Given this list of marker genes Cct6a, Xlr, Hpcal4, Gprin3, Prr14l, Zfp175, Pask, Orc2, Col19a1, Kynu, Zfp280d, Emilin3, Rragc, Bcl10, Spata13, Plxnb3, Prkacb (protein kinase, cAMP dependent, catalytic, beta), Nipbl, Grin1, Tufm, Slc27a1, Orai1, Dhdh, Stxbp2, Ap3b2, Kcnj4, Setbp1, Adgrf2, Pogz (pogo transposable element with ZNF domain), Zswim4 (zinc finger SWIM-type containing 4), Col6a1, Tomm70a, Semp2l1, Plcxd3, Eri2, Alas1, Vsig10, Hspb7, Brcc3, Exph5 (exophilin 5), Rffl, Szrd1, Ctnnd1, Il2ra, Arhgap32, Nsun6, Mllt6, Ahsg, Slc35f1, Acly, Arc, Phaf1, Nme2 (NCBI Gene Id 18103), Ankib1, Rap1gds1, Lyg1, Vps13b, Brat1, Zfp174, Tcta, Senp2, Tab2, St8sia6, Mllt10, Cmtm8, Asb15, Ica1l, Cdk18, Mecp2, Heca, Klhdc7a, Stx5a, Trim16, Nphs2, Syt12, Oscar, Sox14, Mras, Casp2, Metrnl, Skap1, 6430550D23Rik, Slc49a4, Hsbp1l1, Pptc7, Hs3st3b1, Pex14, Cyp2s1, Itga5, Ppp1r10, Creg2, Cd3d, Fads1, Mrgprb2, Cdc14b, here is a description of the gene set: from publication Chen Y, Wang X (PMID 31504780) Mouse Gene Set: MIR_7055_5P species: Mus musculus Genes predicted to be targets of miRBase v22 microRNA mmu_miR_7055_5p in miRDB v6.0 with MirTarget v4 prediction scores > 80 (high confidence targets).